The following is a description of a gene set: Catalysis of an oxidation-reduction (redox) reaction in which a sulfur-containing group acts as a hydrogen or electron donor and reduces oxygen. species: Mus musculus Mouse Gene Set: GOMF_OXIDOREDUCTASE_ACTIVITY_ACTING_ON_A_SULFUR_GROUP_OF_DONORS_OXYGEN_AS_ACCEPTOR, and this is the list of marker genes: Qsox1, Selenbp2, Ero1b, Ero1a, Suox, Selenbp1, Sumf1, Qsox2, Pcyox1l, Gfer, P4hb, Pcyox1